The following is a description of a gene set: Human Gene Set: GOBP_ACETYL_COA_METABOLIC_PROCESS The chemical reactions and pathways involving acetyl-CoA, a derivative of coenzyme A in which the sulfhydryl group is acetylated; it is a metabolite derived from several pathways (e.g. glycolysis, fatty acid oxidation, amino-acid catabolism) and is further metabolized by the tricarboxylic acid cycle. It is a key intermediate in lipid and terpenoid biosynthesis. species: Homo sapiens, and this is the list of marker genes: FASN, PDK4, HMGCS2, DIP2A, ACSS2 (NCBI Gene Id 55902), MVK, ACOT12, PDHA2, DLST, ACSS1, DLAT, MPC2, MLYCD, NUDT8, ACACB, NUDT7, AADAT, AASS, PIPOX, DLD, PDK3, BCKDK, ACACA, ACLY, HMGCS1, PPCS (NCBI Gene Id 79717), PDK1, PDHB, PDK2, TDO2, PDHX, PGK1, ACAT1, PMVK, MVD, PDHA1, TPK1